Given this list of marker genes Defa30, Defa34, Defa41, Defa17 (NCBI Gene Id 23855), Defa29, Defa2, Defa24, AY761185, Defa3, Defa21, Defa25, Defa38, Gm12250, Defa28, Defa40, Gbp2, Defa42, Defa5, Defa22, Defa35, Defa37, Defa39, Defa26, Gbp5, Defa20, Defa31 (NCBI Gene Id 13226), Defa23, here is a description of the gene set: species: Mus musculus Mouse Gene Set: GOBP_DISRUPTION_OF_CELLULAR_ANATOMICAL_STRUCTURE_IN_ANOTHER_ORGANISM The disruption of a cellular component of another organism, leading to damage or temporary subversion of that structure. In some cases this can cause malfunctioning of the cells and death of the target organism.